Given this list of marker genes Npm1, Plk2, Cnot6, Ccna2, Cnot7, Cnot10, E2f7, Ccna1, E2f8, Cdkn1c, Cenpj, Ccnb1, Cnot8, Cdkn1b, Aurka, Ccne1, Cnot4, Sfn, Cdkn1a, Gadd45a, Cdc25c, Cnot3, Cnot6l, Btg2, Cdk2, Cdk1, Ccne2, Cnot2, Cnot1, Cnot9, Pcna, Plk3, Tnks1bp1, Cnot11, Bax, here is a description of the gene set: TP53 Regulates Transcription of Cell Cycle Genes Mouse Gene Set: REACTOME_TP53_REGULATES_TRANSCRIPTION_OF_CELL_CYCLE_GENES studied in species Mus musculus